Given this list of marker genes GLUL, PABPC1, CORO1A, DOCK10, FYB1, GSN, HLA-DRB1, RAP1B, PFN1, CCNL1, PLEK, ABHD12, TPT1, P2RY12, WAS, HLA-DRA, ATP8B4, HLA-DMA, ARPC5, FCGR1A, C1QB, RPS6KA1, MEF2C, CD74, PALD1, DUSP1, ARPC1B, PYCARD, CCL3L3, CPVL, CYTH4, PREX1, STING1, LPXN, CNPY3, SLA, GNB4, GNG5, MYLIP, FPR1, LGMN, PLXDC2, LSP1, ACTB, PRR13 (NCBI Gene Id 54458), BAG3, EVI2A, STXBP2, CREG1, LCP1, MEF2A, VSIR, CD53, CYRIB, TXNIP, RHOB, ACY3, RAB31, BTG2, CSF1R, IKZF1, P2RX4, C3AR1, RNASET2, FOLR2, SNX5, SLC29A1, GRK2, KCTD12, PLD4, GPX1, SCAMP2, TAPBP, FOSB (NCBI Gene Id 2354), TBXAS1, COLGALT1, HCST, GIMAP4, ACTR2, ITSN2, PTPRC, TMBIM6, FCER1G, HCLS1, TLR4, TNFRSF1B, MAF, TACC1, CCL4L2, FOS, ARHGAP30, TMT1A, HLA-A, TMSB4XP8, IL6R (interleukin 6 receptor), CEBPD (NCBI Gene Id 1052), RCSD1, SIGLEC10, ADAM9, LY96, OLR1, CTSC, KIAA0930, LAMP2, CD300A, CTSD, LILRB4 (leukocyte immunoglobulin like receptor B4), MILR1, SAMSN1, CX3CR1, CTSS, MKNK1, RNA5SP151, NFKBIZ, A2M, RNF213, MBNL1, CLEC7A, CASP1, TYMP, SFT2D1 (NCBI Gene Id 113402), NINJ1, DDX5, CAPZB, CD86, UCP2, ANXA5, NAA20, TMIGD3, LPAR5, C3, RUNX1, MERTK, HLA-C, ARHGDIB, CAP1, LST1, RAC1, CD4, GADD45B, TGFBR2, GPSM3, QKI, LY86, SIRPA, PLCB2, HCK, RNASE6, CMTM6, CSF2RA (NCBI Gene Id 8282), ZYX, PTAFR, SAMHD1, TMSB4X, PLAUR (plasminogen activator, urokinase receptor), MYH9, CD14, RB1, SPRED1, IPCEF1, SP100, GAS6, HAVCR2, GATM, CD84, SKAP2, UBC, NFE2L2, DOCK4, HERPUD1, ARHGAP9, AKAP13, RNU1-1, RHOA, H2AC19, LIPA, ARHGAP4, FTLP2, DNAJB1, CD36, IL13RA1, GM2A, MYL12A, EVI2B, ARPC2 (NCBI Gene Id 220721), STK10, NCF4, KLF6, RAP1A, ITM2B (NCBI Gene Id 9445), MYO1F, LGALS9, INPP5D, C12orf75, ZFP36, LAT2, STK4, TREM2, ELF1, HLA-B, B2M, MYO9B, ITGAX, TYROBP, FGL2, NPC2, ITGAM, BIN2, CD37, SIPA1 (NCBI Gene Id 6494), IGSF6, CST3 (NCBI Gene Id 1471), CYBB, MSN, CD164, AP1B1, PPP1R18, SUSD3, APBB1IP, COTL1, ARHGAP25 (NCBI Gene Id 9938), SYNGR2, RAC1P2, LAIR1, CCR1, MGAT4A, SH3BGRL, DOCK2, MGST2, NEK6, SLCO2B1, LPCAT2, TMC6, HSPA1A, ITGB2, PCED1B-AS1, BIN1, ANXA11, ZFP36L2, FTL, MNDA, GPR183, ARHGAP45, CYBA, DOCK8 (dedicator of cytokinesis 8), MIS18BP1, NCKAP1L, GPR34, SWAP70, CXCL16, NR4A2, CEBPB, FCGR2A, MOB1A, ST6GAL1, GNAI2, MPEG1, ZFP36L1, ITPR2, HLA-DMB, RHOG, RGS10, SERP1, OTULINL, IFNGR1, SLC2A3, SYK, VAMP8, ALOX5AP, PTPRE, SPI1, ABCG2, SRGAP2B, NEAT1, GLIPR1, PARP14, HPGDS, CYFIP1, PRKCD, TUT7, BHLHE41, LPAR6, LAPTM5, C1QC, CMTM7, IER5, LAP3, RGS1, FCGR3A, ABI3, GAL3ST4, SAT1, LINC00996, OSTF1, AOAH (NCBI Gene Id 313), SPP1, AIF1, KLF2, FCGRT, PLEKHO1, GRB2, SRGAP2, TLN1, MS4A7, PPP1R15A, CD83, IRF8, ACTR3, ENTPD1, SH3KBP1, PIP4K2A, SGK1, RHBDF2, PSAP, ADAM28, ATF3, LIMS1, MED12L, CDKN1A, STAB1, BLNK, EFHD2, LYN, CIB1, TNFRSF1A, C1QA, NPL, SRGN, RGS19, CHCHD7, B3GNT5 (UDP-GlcNAc:betaGal beta-1,3-N-acetylglucosaminyltransferase 5), TLR10, ARRB2, SMAP2, OAZ1, HLA-DPA1, GMFG, ATP6V0E1, ALOX5, SH2B3, ETS2 (ETS proto-oncogene 2, transcription factor), TAGAP, SORL1, SELPLG, S100A11, LCP2, ARPC3, ADORA3, CXCL8, IFI16, KLF3, MFSD1, CPED1, VAV1, FGD2, NFKBIA, GLRX, PARVG, GNA13, TRIM38, ADAP2, TMEM52B, PPT1, HMOX1, IL6ST, PLSCR1, TMSB4XP4, CSF3R, FMNL3, P2RY13, CTSB, RGS2, HSPA1B, OLFML3, VSIG4, GRN, OGFRL1 (NCBI Gene Id 79627), ARHGAP27, SFMBT2, IL10RA, JUNB, HLA-E, here is a description of the gene set: species: Homo sapiens Retinal Microglia from publication Hu Y, Wang X, Hu B, Mao Y, Chen Y, Yan L, Yong J, Dong J, Wei Y, Wang W, Wen L, Qiao J, Tang F (PMID 31269016) Human Gene Set: HU_FETAL_RETINA_MICROGLIA